The following is a description of a gene set: Mouse Gene Set: MIR_5101 from publication Chen Y, Wang X (PMID 31504780) studied in species Mus musculus Genes predicted to be targets of miRBase v22 microRNA mmu_miR_5101 in miRDB v6.0 with MirTarget v4 prediction scores > 80 (high confidence targets)., and this is the list of marker genes: Itpripl2, Btc, Paqr8, Nipal2, Gmeb1, Ahdc1, Fzd10, Tpmt, Cdh2, Trpm1, Zfp568, Skic2, Xcr1, Pou3f3, Hmcn1, Ciita, Xpr1, Chic1, Dusp3 (dual specificity phosphatase 3 (vaccinia virus phosphatase VH1-related)), Tecpr2, Lypla1, Sec63, Tfap4, Adamtsl1, Steap2, Synj2bp, Thnsl1, Lrrc14b, Katnip, Pkia, Ston2, Foxa2, Tsx, Rell1, Atn1, Zbtb44, Scn8a, Cadm2, Bbx, Foxp1, Nrk, Barhl1, Ncam1, Ppp3ca, Ccnd2, Enpp2, Heatr6, Mei4, Fst, Crebrf, Nt5e, Capn6, Strbp, Mras, Uchl4, Ldlrad2, Kcna2, Ywhab, Zfhx3, Tead1, Nsd3, Cox7b2, Zfp563, Prnd, Tent5a, Slc18a1 (NCBI Gene Id 352946), Pde5a, Sdc2, Lsm11, Vamp5, Megf10, Lin7a, Il5ra, Pcdh9, Fosb, Tet2, Onecut2, Klf11, Ndst3, P2ry4, Cdc42, Dnmt3a, Zbtb18, Ntrk3, Egln1, Ttk, Eif5a2, Erc2, Ap2m1, Magi3, Efhc2, Edaradd, Glod4, Mfsd4a, Med28, Zfp385b, Dnajc3, Muc15, Ola1, Lrrtm1, Gja3, Spc24, Zfp108, Tmem70, Grik3, Dusp10, Dppa2, Ttc9c, Rnf115, Lancl3, Esp31, Tmem79, Gnal, Igsf1, Cadm1, Prrt2, Hook1, Slc7a11, Zfp536, Ube2a, Lcorl, Slitrk1, Spic, Nalf1, Pus7, Ptpn7, E2f3, Aebp2, Hps3, Aoc3, Slc12a6, Fkbp2, Kif23, Skil, Cox15, Dram2, Grm5, Fryl, Arhgap25, Tef, G3bp2, Agbl3, Arhgef28, Rsf1, Diaph2 (NCBI Gene Id 54004), Jade1, Glb1l3, Zfp346, Pdlim5, Prlr, H2bw2, Abcc9, Ppm1h, Scn5a, Ptgs2, Ednrb, Fgfr1, Cmtm4, Fam111a, Ogn, Rab6a, Speg, Kpnb1, Fam177a2, Slc39a10, Mfsd2b, Etv6, Fgf16, Phldb2, Prkar2b, Fam124b, Adamts5, Pnpla8, Abhd15, Grm3, Pcmtd1, Pitpnc1, Tgfb1i1, Gm12253, Cebpg, Vps26b, Eya4, Rasgrp3, Ublcp1, Dnajc6, Tob2, Dcdc2a, Ptchd1, Nrxn3, Dnal1, Slc43a3, Lyve1, Oasl2, Sp9, Tmf1, Kctd1, Cldn34c1, Bnc2, Agtrap, Slc8a1, Ercc4, Aldh9a1, Lrp3, Urb2, Nr4a3, Rnf144a, Adsl, Megf11, Kdm7a, Ttbk2, Klrb1f, Epha10, Rbms3, Stox2 (storkhead box 2), Septin11, Pgm2l1, Esp34, Socs2, Nup155, Stag2, Rgs17, Plin5, Pou2f1, Slc44a3, Zbtb20, Cacnb4 (NCBI Gene Id 73120), Itih5, Isoc1, Zfp503, C1qtnf3, Egfr, Rnf139, Hsf2bp, Adam28, Actn4, Ano1, Ddx3x, Rint1, Rxrg, Fzd4, Serpinb10, Sox4, Dnajb9, Bcl2, Cers3, Mysm1, Dact1, Ebf1, Ptchd4, Six3, S1pr1, Utrn, Dnmt3b, Il13ra1, Ankrd34b, Pros1, Car8, Sytl2, Arrdc3, Mdga2, Grik2, Ssr1, Cd55, Capn8, Creg2, Uox, Tbx3, Gpr150, Llph, Liph, Vtcn1, Six6, Dnm1l, Agap1, 6030458C11Rik, Erbb4, Atosb (atos homolog B), F11, Traf6, Mtf1, Osbpl8, Arpc4, Ptprb, Pak3, Krt26, Chp1, Epha4, Ark2c, Ikzf2, Ldlrad3, Sprr2a1, Acnat1, Ppbp, Abhd6, Glt8d2, Tfap2b, Pi15, Lig4, Cacna1c (NCBI Gene Id 619317), Pfkfb2 (6-phosphofructo-2-kinase/fructose-2,6-biphosphatase 2), Cdh12, Id1, Nfib, Hcn1, Cep41, Pcdh7, Plxdc2, Cks1brt, Srsf10, Cd300ld, 9330159F19Rik, Klhl1, Foxg1, Kif1b, Opn4, Pitrm1, Poc5, Mxi1, Calm3, Prxl2a, Eri2, Ppp1r3a, Foxa1, Elk3, Acvr1b, Mmp19, Gphn, Pabir1, Alox12, Slc16a14, Mettl14, Iws1, Nav1, Cdkal1, Flrt2, Fras1, Noct, Tmem30a, Marchf5, Zeb2, Rapgef4, Pla2g2d, Pcdh8 (protocadherin 8), Cramp1, Atp2b1, Ints12, Sprr2a2, Armc8, Slc22a15, Scoc, Wdr31, Kalrn, Inip, Dip2c, Dlgap5, Mcidas, Slc10a7, Rnase9, Sobp, Fbn2, Crppa, Fgf20, Pdzd7, Ajap1, Sgtb, Haus2, Slco1a5, Azi2, Zmiz1, Rpp25, Cachd1, Nr4a2, Atf6, Ntrk2, Pyurf, Sfxn4, Slc25a36, Dars2, Tiparp, Scn3a, Sema3c, Grem1 (gremlin 1, DAN family BMP antagonist), Pcdh17, Tspyl4, Ube2h, B230219D22Rik, Hivep3, Camta1, Adgrl3, Esyt3, Ikzf3 (IKAROS family zinc finger 3), Fbxo32, Tmod2, Dpysl3, Sspn, Sgo1, Kcna1, Tgtp1 (T cell specific GTPase 1), Insr, Cdc14b, Etv5, Rs1, Htr2b, Map6, Syn3 (synapsin III), Pou2af3, Cdc25c, Caskin1, Msi2, Cdc42ep3, Celsr2, Edf1, Adap2, Apold1, Isl1, Stk40, Tspan18, Camk2b, Lims1, Myadm (NCBI Gene Id 50918), Atxn7, Clxn, Kcnj12, Klf8, Atp8b1, B4galt6, Unc79, D1Pas1, LTO1, Sppl2a, Calb1, Abcd2 (NCBI Gene Id 26874), Rab11fip1, Gpbp1, Hook3, Col23a1, Gpi1, Gpd2, Kcna5, Prrg4, Pou2f2, Rbm41, Ids, Jam2, Pou3f2, Celf2, Nlgn1, Il1b, Pax9, Fntb, Slc16a10, Ube4b, Robo1, Hpgds, Cnksr2, Arhgef3, Usp31, Rora, Eps15, Rnaseh2a, Lrrc4, Lgalsl, Psrc1, Maf, Car3, Ncor1, Fam120a, Slco3a1, Ccr4, Gm4297, Fbxw7, Crim1, Acer3, Atp11c, Map3k2, Lrrc28, Slc6a6, Pdzd8, Ckap4, Tnfsf13, Bcl11b, Zfp111, Utp14b, Zyg11b, Cdo1, Eml5, Tnrc6b (NCBI Gene Id 72625), Mfhas1, Slc7a14, Ralgps1, Lamp3, Abi3, Lpp, Ugdh, Nol4, Gnaq, Csde1, Ythdf1, Tubal3, Ranbp10, Adam19, Arid1b, Wnt9a, Marchf1, Tfcp2l1, Baz2a, Abcb1b, Zfp445, Zcchc4, Ppargc1a, Zfp612, Ddx18, Prol1, Prrg3, Jarid2 (NCBI Gene Id 97879), Gnpat, Prdm9, Pik3r3, Rbsn, Chrna1, Mtf2, Eif3j2, Dkc1 (dyskeratosis congenita 1, dyskerin), Ndufaf7, Parp2, Tbc1d24 (NCBI Gene Id 224617), Ttc39a, Gldn, Mta1, Iffo2, Ccdc120, Eomes, Tasor2, Ubxn2a, Rab10, Tmed5, Synrg, Trpc4, Fam168b, Prrx1, Klf4, Vcpip1, Rbm39, Sema3e, Brd3, Plekha3, Aak1, Armc6, Tafa2, Ror1, Ppp2r5e, Far2, Ttyh1, Pde1a, Mab21l2, Sox9, Tgtp2, Ica1l, Sowaha, Zfp704, Synj1, B3galt5, Setd7, Tbc1d8b, Rbmx2, Trmt2b, Sacm1l, Bdnf, Rhpn2, Galnt13, Mc3r, Hsbp1l1, Cmip, Apol10a, Pet100, Btg2, Pax3, Ctbp2, Celf5, B230217C12Rik, Prr11, Lin28b, Bambi, Atf7, Vps13b, Lima1, Sytl5, Hoxc13, Ddx21, Jag2, Sfmbt1, Kcnh1, Usp32, Cep170, Ets1, Tmem167, Rbmx, Nfia, Atp1b2, Samd11, Camk4, Atp8b4, Ms4a4c, Celf4, Sipa1l1, Prkx, Ptgr3, Fgf18, BC016579, Cntnap3, Bahcc1, Gxylt1, Brwd3, Cebpzos, Taf4b, Lbh, Gapt (Grb2-binding adaptor, transmembrane), Ccr9, Cdh4, Tlcd2, Map1b, Fgd5, Mmp20, Daam1, Bcl11a, Kmt5a, Qrfp, Mpp7, Ptgs1, Sema5a, Fam168a, Lrrtm3, Dcaf17, Odr4, Gsk3b, Ephb2, Ar, Cntn1, Lrrc3, Fstl4, Tnrc18, Slamf7, Tmem132b, Esr1, Tmem44, 4921524J17Rik, Zfp462, Frk, Utp6, Ccdc77, Abca1, Tmcc1, Magi1, Tnfsfm13, Dcbld1 (NCBI Gene Id 66686), Chrdl1, Rfx3, Thsd4, Gpc6, Dyrk1a, Slc24a2, Nacc2, Hyal1, Prtg, Fam178b, Gal3st2c, Ugcg, Lrrc4c, Gm8369, Phox2b, Faxc, Rpgrip1, Pard3b, Ceacam1, Ttc41, Kcnd2, Pfkfb4, Spats2l, Itgb8, Ms4a2 (NCBI Gene Id 14126), Dock8, Mrtfa, Dach1, Cacng2, Purb, Foxf1, Rlim, Fam181b, Jakmip2, Dsc3, Psmb11, Ly6m, Esrrg, Shprh, Desi1, Tnrc6c, Epha7, Zmynd8, Rab27b, Flvcr1, Derl1, Kif26a, Cdnf, Zfp933, Cxcl13, Ttc39b, Zfp882, Smc5, Pdss2, Trim60, Tcf4, Hs3st3b1 (NCBI Gene Id 54710), Nr3c1, Cbln2, Hnf4a, Ddx11, Chrnb4, Anp32a, Rasgrf2, Arhgap28, Unc5d, Cxcr2, Mecp2, Jph3, Rbfox1, Mre11a, Tenm4 (NCBI Gene Id 97426, teneurin transmembrane protein 4), Nrxn2, Slfn5, Galntl6, Tril, Elf1, Naaladl2, Exosc1, Carf, Acod1, Aurkb (NCBI Gene Id 20877), Nudt16, Sntg1, Uggt1, Klf6, Camkk2, Tppp, Slc38a6, Sdcbp, H2-Eb2, Ankrd49, Tet1, Fam177a, Rnf150, Nrxn1, Ptprd, Tmem45a2, Ccl28, Col27a1, Tafa3, L1cam, Hnrnpr, Garem1, Nedd4l, Gria2, A630001G21Rik, Stx17, Unc13c, Gabrb2, Gm5934, Foxb1, Xkr6, Hdgfl3, Pappa, Pde1c, Cstad, Qki, Zfp735, Atxn1, Tmem42, Mctp2, Tenm2, Ncam2, Gbp7, Mapk10, Lhx5, Trip12, Cpsf2, Ubn2, Slco1c1, Fut9, C2cd2l, Sorcs1, Slc23a1, Bub1, Calr, Zdhhc14, Unc13a, Tmem67, Nfic, Uvssa, Cd93, Ywhae, Aqp4, Acta1, Mr1, Dnajc18, Secisbp2l, Ttc38, Rufy3, Neurod2, Pik3ca, Hip1, Rab15, Kcnj13, Nr2c1, Fgfbp3, Kitl, Emx2, Emc4, Ago4, Fnd3c2, Rad18, Chl1, Slc16a9, Ppara, Mctp1, 1700093K21Rik, Gna15, Igsf10, Rad51d, Ing3, Aoc1, Hs6st2 (NCBI Gene Id 50786), Pakap, Elavl3, Sesn2, Cyld, Pcdh19, Smc6, Elavl4, Apobec1 (NCBI Gene Id 232352), Acot3, Pnma3, Zfp874b, Tmem164, Grip1, Hif1a, Gria4, Papolg, Gpr55, Kat2b, Peli2, Cnot6l, Lrrc2, Rimbp2, Dsg2 (NCBI Gene Id 52489), Tmem140, Mrc2, Plekhb2, Abat, 1700012B09Rik, Mef2a, Bsn